The following is a description of a gene set: species: Mus musculus Cytokines mediate cell-cell communication in the immune system and represent important therapeutic targets. A myriad of studies have highlighted their central role in immune function, yet we lack a global view of the cellular responses of each immune cell type to each cytokine. To address this gap, the authors created the Immune Dictionary, a compendium of single-cell transcriptomic profiles of more than 17 immune cell types in response to each of 86 cytokines (>1,400 cytokine-cell type combinations) in mouse lymph nodes in vivo. A cytokine-centric view of the dictionary revealed that most cytokines induce highly cell-type-specific responses. For example, the inflammatory cytokine interleukin-1β induces distinct gene programmes in almost every cell type. A cell-type-centric view of the dictionary identified more than 66 cytokine-driven cellular polarization states across immune cell types, including previously uncharacterized states such as an interleukin-18-induced polyfunctional natural killer cell state. from publication Cui A, Huang T, Li S, Ma A, Pérez JL, Sander C, Keskin DB, Wu CJ, Fraenkel E, Hacohen N (PMID 38057668) Genes positively differentially expressed in cell type: B cell upon treatment with cytokine: IL-18 in mouse lymph nodes in vivo. Mouse Gene Set: CUI_B_CELL_IL18_RESPONSE_UP, and this is the list of marker genes: Eif2ak2, Ctss, Casp4, Socs1, Nampt, Gimap9, Tprg1l, Psmb10, Zfp945, Dph3, Irf1, H2-T22, Parp9, Jun, Gbp5, H2-Q4, Plaat3, Ogfr, Mrpl46, Ifi203, Rtp4, Samhd1, Pa2g4, Gbp3, Man2a1, Psme1, Ly6a, Serpina3f, Psma5, Bst2, H2-K1, Gimap4, Xaf1, Pkib, Elk4, Slamf7, Ffar1, Irgm2, Irf8, Parp14, Mcl1, Ak6, Wars1, Stat1, Katna1, Pml, Idnk, Stat3, Sertad2, Psma7, Tgtp2, Rnase6, Serpina3g, Tapbpl, Cflar, Mrps34, Phf11b, Zbp1, Ppa1, Ifi47, Mpeg1, H2-T23, Trim12c, Thoc2l, Gbp2, Gbp9, Stat2, B2m, Hadhb, Calhm6, Slfn2, Plac8, Ctsc, Got1, Psme2, Atp5f1b, Gimap3, Gimap7 (GTPase, IMAP family member 7), Icam1, Serpinb1a, Gbp7, Vmp1, Bcl7c, Hspa1a, Eif1b, Iigp1, Agfg1, Ms4a4c, Tap1, Irgm1, Gbp4, Nrip1, Psmb8, Mndal, Nlrc5, Igtp, Irf9, Psmb9, Tap2